Given this list of marker genes Htr2b, Pdgfb, Htr2a, Pdgfa, Htr2c, here is a description of the gene set: Any process that modulates the frequency, rate or extent of the chemical reactions and pathways resulting in the formation of phosphatidylinositol. Mouse Gene Set: GOBP_REGULATION_OF_PHOSPHATIDYLINOSITOL_BIOSYNTHETIC_PROCESS studied in species Mus musculus